The following is a description of a gene set: The series of molecular signals generated as a consequence of a fibroblast growth factor receptor binding to one of its physiological ligands resulting in an increase in the rate or frequency of a MAPKKK cascade. Human Gene Set: GOBP_POSITIVE_REGULATION_OF_MAPKKK_CASCADE_BY_FIBROBLAST_GROWTH_FACTOR_RECEPTOR_SIGNALING_PATHWAY species: Homo sapiens, and this is the list of marker genes: FGF23, KL, KLB, FGF21, FGFR1